Given this list of marker genes Vegfa, Mob3b, Chac1, Zfp367, Phf20, Tmcc1, Rasgef1b, Htr4, Cd2ap, Kif5b, Zswim3, Sall4, Pnoc, Gm12886, Itpr1, Adgrl1, Ccne1 (NCBI Gene Id 12447), Usp25, Peli3, Atxn1l (NCBI Gene Id 78838), Slitrk6, Plxnc1, Pam, Nudt7, Rab11fip1, Ptprr, Dsel, Acvr2b, Erlin2, Polr3f, Arhgdia, Zfhx3, Spsb4, Dennd10, Atxn2, Prkar2a, Rbm6, Zbtb44, Cpsf7, Gcc2, Tbl1xr1, Dixdc1, Shoc2, Sik1, Usp12, Lrrc32, Cfap45, Srpra, Nectin1, Rfx3, Lrig1, Zfhx4, Atp2b2, Higd1a, Iars1, Mex3c, Krtap11-1, Pafah1b1, Selenoi, Cops7b, Ago1, Kif23, Sptbn2, Pwwp2b, Nfatc3, Cacna2d1 (NCBI Gene Id 12293), Etnk1, Cdk17, Fbxo21, Bace1, Dclk1, Omg, Lats1, Med1, Cmpk1, Ppp1r11, 1700025G04Rik, Fermt2, Sema6d, Btrc, Ubn2, Hephl1, Setd3, Capns1, Clock, Mgat4a, Fbln5, Igf2r, Pdxk, Rab9b, Mmd, Prmt6, Zmym2, Tnrc6b, Akt3, Il10ra, Map2k1, Pth, Myb, Pou2f1, Xpo7 (exportin 7), Socs6, Wnt3a, Kif1b, Cyp26b1, Ret, Ccdc6, Gbp2b, Arhgap12, Rubcn (NCBI Gene Id 67910), Plekhh1 (pleckstrin homology domain containing, family H (with MyTH4 domain) member 1), Idh3a, Spryd3, Ippk, Ccdc85b, Nup50, Pnp2, Suco, Rnf144b, Plxna4, Zfp809, Slc7a2, Kcnk10, E2f3, Armcx6, Sez6l, Ccnt2, Ube4b, Onecut2, Colq, Pik3r1, Bcl2l2, Sel1l3 (sel-1 suppressor of lin-12-like 3 (C. elegans)), Otx1, Luzp1, Cert1, Hmga1, Krtap26-1, Akap11, Scoc, Spag7, Phip, Il7r, Sox6, Tmem135, Chd2, Phf19 (NCBI Gene Id 76981), Rere, Zcchc3, Cnot6l, Garem1, Stxbp3, Ccnd2, Nrbp1, Ppp2r1b, Rab10, Mybl1, Rasef, Bcl2, Entpd7, Ash1l, Tab3, Fgf7, Atf6 (NCBI Gene Id 78907), Phc3, Stradb, Nrn1, Fam151b, Kl, N4bp1, Actr2, Adgrl2, Nufip2, Sall1, Usp14, Mlycd, Trabd2b (NCBI Gene Id 666048), Ywhah, Crebl2, Seh1l, Cdc25a, Abtb2, Hectd1, Prrc2c, Slc4a4, Ccr2, Rreb1, Kdsr, Kcnj2, Septin2, Slc25a22 (NCBI Gene Id 68267), Usp15, Mfn2, Ppm1e, Pacsin2, Son, Ahcyl2, Cdk12, Klc1, Ankrd13b, Pappa, Plcxd2, Fgf9, Casr, Slc20a2, Prdm4, Pnpla6, Klc4, Ano3, Avl9, Cpd, Tlk1, Med26, Arfgap2, Cdc37l1, Sec61a1, Capn6, Sesn1, B4galt1, Nudt4, Kpna1, Slit2, Ythdc1, Nlrx1, Bmpr1a, Reck, Adrb2, Raf1, Nos1, Trank1, Hapstr1, Cpeb2, Dnajc16, Znrf2, Eda, Smim13, Kif5c, Nav1, Tgfbr3, Gm5460, Erc2, Ptpn3, Col12a1, Kif1c, Caprin1, Adamts3, Dcp1a, Cntnap1, Slc6a11, Lrig2, Pappa2, Zfp449, Rarb, Apln, Aar2 (NCBI Gene Id 68295), Sgk1, Cacul1, Syde2, Tacc1, Zbtb34, Plxna2, Rictor, Wnt7a (wingless-type MMTV integration site family, member 7A), Desi1, Klhl2, Unc80, Plekhm3, Axin2, G0s2, Cdk5r1, Rad23b, Pla2g15, Pip4p2, Penk, Crebrf, Wbp11, Rnf217, Wee1, Rnf10, Amotl1, Phactr2, Armh4, Tenm2, Rfc1, Eif3a (eukaryotic translation initiation factor 3, subunit A), Slc13a3, Clspn, Gpr63, Ddx3x, Ncapg2, Hoxa10, Fbxw7, Angel1, Fmn2, Islr (NCBI Gene Id 26968), Dcaf7, Nol4l, Mapkap1 (mitogen-activated protein kinase associated protein 1), Sec14l1, Aff4, Atxn7l3, Cobll1, Plpp1, Kmt2a, Qki, Kbtbd2, Akap7, Chek1, Arih1, Spred1, Pip4p1, Tbpl1, Zfp622, Cdca4, Tmem74b, Usp42, Tuba4a, E2f7, Eya1, Traf3, Smurf1, Dll1, Abl2, Btg2, Ell, Sema3a, Cpeb3, Jarid2, Ubfd1, Ago4, Lhx3, Slc39a10, Acvr2a, Gpatch8, Wipi2, Ankrd33b, Grm7, Smad7 (SMAD family member 7), Ist1, Nup210, Myt1l, Zbtb39, Slc4a7, Tll1, Dync1li2, Lurap1l, Adissp, Atp1b4, Atp7a, Bicd1, Usp31, Wwp1, Epha7, Rubcnl, Arl2, Cc2d1b, Anks1, Helz, Reln (NCBI Gene Id 19699), Ghr, Trp53inp2, Satb2, Ccnjl, Ncs1, Chpt1, Ppp6c, Kif21a, Lrp6, Nuak2, Wnk3, Cbfa2t3, Drd1, here is a description of the gene set: species: Mus musculus from publication Chen Y, Wang X (PMID 31504780) Genes predicted to be targets of miRBase v22 microRNA mmu_miR_1907 in miRDB v6.0 with MirTarget v4 prediction scores > 80 (high confidence targets). Mouse Gene Set: MIR_1907